The following is a description of a gene set: NFE2L2 regulates pentose phosphate pathway genes studied in species Homo sapiens Human Gene Set: REACTOME_NFE2L2_REGULATES_PENTOSE_PHOSPHATE_PATHWAY_GENES, and this is the list of marker genes: CREBBP, NFE2L2, TALDO1, MAFG, TKT, EP300, G6PD, PGD